The following is a description of a gene set: species: Mus musculus The aggregation, arrangement and bonding together of two or more different receptor complexes that individually undergo combination with a hormone, neurotransmitter, drug or intracellular messenger to form a higher level receptor complex. The formation of the higher level complex initiates a change in cell function. Mouse Gene Set: GOMF_RECEPTOR_RECEPTOR_INTERACTION, and this is the list of marker genes: Htr1a, Adrb2, Fgfr1, Fgf20, Fgf2